The following is a description of a gene set: Mouse Gene Set: ZHOU_PANCREATIC_EXOCRINE_PROGENITOR from publication Zhou Q, Brown J, Kanarek A, Rajagopal J, Melton DA (PMID 18754011) Transcription factors expressed in progenitors of exocrine pancreatic cells. studied in species Mus musculus One goal of regenerative medicine is to instructively convert adult cells into other cell types for tissue repair and regeneration. Although isolated examples of adult cell reprogramming are known, there is no general understanding of how to turn one cell type into another in a controlled manner. Here, using a strategy of re-expressing key developmental regulators in vivo, we identify a specific combination of three transcription factors (Ngn3 (also known as Neurog3) Pdx1 and Mafa) that reprograms differentiated pancreatic exocrine cells in adult mice into cells that closely resemble beta-cells. The induced beta-cells are indistinguishable from endogenous islet beta-cells in size, shape and ultrastructure. They express genes essential for beta-cell function and can ameliorate hyperglycaemia by remodelling local vasculature and secreting insulin. This study provides an example of cellular reprogramming using defined factors in an adult organ and suggests a general paradigm for directing cell reprogramming without reversion to a pluripotent stem cell state., and this is the list of marker genes: Sox9, Hnf1b, Hnf4a, Mnx1, Hhex, Ptf1a, Foxa2 (NCBI Gene Id 15376), Onecut1, Prox1, Nr5a2, Pdx1